The following is a description of a gene set: An abnormality of Sharpey's fibers (bone fibers, or perforating fibers), which are a matrix of connective tissue consisting of bundles of strong collagenous fibers connecting periosteum to bone. species: Homo sapiens Human Gene Set: HP_ABNORMAL_SHARPEY_FIBER_MORPHOLOGY Abnormal Sharpey fiber morphology, and this is the list of marker genes: PTPN22, ENPP1 (ectonucleotide pyrophosphatase/phosphodiesterase 1), CLCNKB, HYAL1, IL2RB, DMP1, STAT4, WRN, AP2S1, MEN1, IL2RA, ATP7B, GCM2, ANKRD55, PTPN2, TNFRSF11B, GNA11, PDGFRB, KCNJ1, NOTCH3, SLC12A1 (NCBI Gene Id 6557), CDC73, HLA-B, LMNA, TNFRSF1A, CD247, PHEX, FXYD2 (FXYD domain containing ion transport regulator 2), MEFV, ALPL, ANKH, SLC12A3, ATP7A